The following is a description of a gene set: Human Gene Set: HP_ABNORMALLY_FOLDED_HELIX Any structural anomaly of the border of the helix, which usually forms a rolled rim but is highly variable in shape. species: Homo sapiens Abnormally folded helix, and this is the list of marker genes: BHLHA9, DACT1, AHDC1, GP1BB, TCF3, ZFX, RNU4-2, FOXP2 (NCBI Gene Id 93986), ZNF462, SCARF2, EBF3, PIGN, COMT, HSPG2, FBN2, CHD7, NFIA, BICRA, RPS23, HIRA, BCOR, ZMYND11, PYCR2 (NCBI Gene Id 29920), ERF, SLC6A8, DDX6, PGM2L1, TMEM94, FGFR2, PPP1CB, CPT2, TBX1, GNAI3, NAA10, NFIX, EBP, CLIC2, COL2A1, CBL, TUBB, FN1, SEMA3E, HOXA2, GNB1, CTCF, KDM6A, SMC1A, MAPRE2, TFAP2A, SLC26A2, RECQL4, JMJD1C, TBX2, TWIST1, UFD1, EFTUD2, FREM1, SALL1, CHUK, SLC16A2, CDK13, AGO2, SCNM1, ARVCF (NCBI Gene Id 421), TGFB3, PIGB, MED12 (mediator complex subunit 12), POGZ, PIGA, SEC24C, TRIO, CSPP1, KMT2D, PIGL, ASXL2, TASP1, CREBBP, ACTB, AMMECR1, CSNK2A1, FZD2, KCTD1, KANSL1, VPS51, LONP1, PLCB4, AMER1, PPP2R3C, RREB1, BCL11A (BCL11 transcription factor A), NARS1, LZTR1, FANCB, KIAA0586